The following is a description of a gene set: HBV HBx to CREB-mediated transcription. Pathway ID: N00544. Pathway type: Pathogen. Pathway class: nt06263 Hepatocellular carcinoma. species: Homo sapiens Human Gene Set: KEGG_MEDICUS_PATHOGEN_HBV_HBX_TO_CREB_MEDIATED_TRANSCRIPTION Pathway Definition from KEGG: X -> CREBBP == (CREB+ATF2) => (CXCL8,PCNA), and this is the list of marker genes: CREB3, ATF6B, ATF4, PCNA, CREB3L1, CREB3L3, CREB3L4, CREB3L2 (cAMP responsive element binding protein 3 like 2), ATF2, CREB1 (NCBI Gene Id 1385), CREBBP, CXCL8, CREB5